Given this list of marker genes OPA3, MT-ND4L, KCND3, LMNB1, POLR3A, MT-ND5, BSCL2, TH, MT-ND6, TPP1, ALDH18A1, PRDX3, CYP7B1, MT-ATP6, NDUFS2, FUS, MYBPC1, MFN2, MPZ, REEP2 (receptor accessory protein 2), ATXN2, NIPA1, COQ2, PPP2R2B, SETX, ATXN1, MT-CO3, GRIK2, PIK3R5, COQ4, MT-ND2, MT-CO1, FMR1, ANO3, POLR3B, PDGFB, CARS2, TUBB4A, GCH1, DRD3, SCARB2, DNAJC30, NR4A2, SPG11, NOTCH2NLC, VAPB, NPTX1, PRKN, COL6A3, MT-ND1, PIGA, STUB1, MT-CYB, UCHL1, PMP22, PTRHD1, TENM4 (teneurin transmembrane protein 4), PLA2G6, TMEM240, PARK7, TSPOAP1, CACNA1G, NDRG1, ATP13A2, ITPR1, RILPL1, MT-ND4, IMPDH2, GALT, PRKRA, FGF14, here is a description of the gene set: Human Gene Set: HP_POSTURAL_TREMOR species: Homo sapiens A type of tremors that is triggered by holding a limb in a fixed position. Postural tremor